The following is a description of a gene set: studied in species Homo sapiens Human Gene Set: GOBP_REGULATION_OF_DENDRITIC_CELL_CHEMOTAXIS Any process that modulates the frequency, rate or extent of dendritic cell chemotaxis., and this is the list of marker genes: SLAMF8, GAS6, SLAMF1, LGALS9, C1QBP, CCR6, CCL21, CALR, IL12A, SPI1, TNFSF18, CCR7